The following is a description of a gene set: studied in species Homo sapiens Any process that modulates the frequency, rate or extent of the regulated release of saliva from a cell or a tissue. Human Gene Set: GOBP_REGULATION_OF_SALIVA_SECRETION, and this is the list of marker genes: NEGR1, NEUROG1, DCANP1, FGF10, OPRK1, TIFAB, PPP3CA, AQP1